The following is a description of a gene set: from publication Cao J, O'Day DR, Pliner HA, Kingsley PD, Deng M, Daza RM, Zager MA, Aldinger KA, Blecher-Gonen R, Zhang F, Spielmann M, Palis J, Doherty D, Steemers FJ, Glass IA, Trapnell C, Shendure J (PMID 33184181) studied in species Homo sapiens Human Gene Set: DESCARTES_FETAL_PLACENTA_LYMPHOID_CELLS Marker genes curated from the annotated cluster as represented in the Descartes Human Gene Expression During Development database. The gene expression program underlying the specification of human cell types is of fundamental interest. The study authors generated human cell atlases of gene expression and chromatin accessibility in fetal tissues. For gene expression, the study authors applied three-level combinatorial indexing to >110 samples representing 15 organs, ultimately profiling ~4 million single cells. The study authors leveraged the literature and other atlases to identify and annotate hundreds of cell types and subtypes, both within and across tissues. Our analyses focused on organ-specific specializations of broadly distributed cell types (such as blood, endothelial, and epithelial), sites of fetal erythropoiesis (which notably included the adrenal gland), and integration with mouse developmental atlases (such as conserved specification of blood cells). These data represent a rich resource for the exploration of in vivo human gene expression in diverse tissues and cell types., and this is the list of marker genes: TRAT1, STYK1, NLRC3, KLRG1, PLCH2, TIGIT, SH2D1B, CST7, CDKN2A, IGHA1, DAPK2, GZMB, WDR62, TRBC2, RUNX3, OASL, CDHR1 (NCBI Gene Id 94000), EOMES, RASA2-IT1, NOD2, ENAM, ZBP1, TRAF3IP3, SIRPG, ZNF215, PTGIS, CD3D, CTSW, LAX1, ITGAD, GZMH, CD52, CD3G, IL32, IKZF3, PTPN7, ITGB7, KLRB1, CD6, IFNG-AS1, ITK, SLAMF6, CD244, AKNA, KLRA1P, NUGGC, KIF11, SH2D2A, IGHGP, CD79B, SEPTIN1, ITGA8, KLRC2, APOBEC3D, IGLL5 (NCBI Gene Id 100423062), SCML4, DTHD1, TXNDC5, TRGC2, XCL2, SLFN12L, CARD11, CD27, TMIGD2, IGHG4, ADGRG3, CD2, GZMK, CD79A, GZMA, LTB, JCHAIN, STAP1, PSTPIP1 (proline-serine-threonine phosphatase interacting protein 1), MYO1G, LCK, SIDT1, FBXO43, IGHG1, PTGDR, IGKC, LINC00426 (NCBI Gene Id 102723372), MZB1, JSRP1, CXCR3, ALOX5AP, CD7, IGHM, TRAF5, LINC01934, NMUR1, CLDND2, NKG7, ANKRD20A9P, TOGARAM2, CEP55, PTPRCAP, FCRL5, THEMIS, CARMIL2, LINC00861, IL2RG (interleukin 2 receptor subunit gamma), CAMK4, RASGRP1, CD5, PIM2, CRTAM, TSHR, CD247, ADGRG5, KLRC1, CD38, POU2AF1, RHOH, GNPTAB, GNLY, LINC01484, TBC1D10C, ISG20, CD3E, IRF4, KCNQ5, DENND1C, IGHG3, CD8A, SAMD3, SH2D1A, ANKRD36BP2, PRF1, TMEM71, CD69, ZAP70, BCL11B, KLRC4-KLRK1, TNFRSF18, XCL1, ZNF683, TRDC, KLRC3, LINC02362, GIPR, NCR1, CD96, VAMP1, RASAL3